Given this list of marker genes Cacnb1, Cacnb3, Sestd1, Ubr3, Cacng1, Rem1, G6pdx, Pde4d, Camk2d, Cacna1d, G6pd2, Bin1, Cacnb2, Fbxo11, Cacng6, Cacna2d1, Cacna1c, Nppa, here is a description of the gene set: Mouse Gene Set: GOBP_CALCIUM_ION_TRANSMEMBRANE_TRANSPORT_VIA_HIGH_VOLTAGE_GATED_CALCIUM_CHANNEL species: Mus musculus A process in which a calcium ion is transported from one side of a membrane to the other by means of a high voltage-gated calcium channel.